Given this list of marker genes Txk, Nfatc3, Ccl5, Naa10, Ddx50, Bin1, Pnisr, Ubald1, Nck1, Pnrc1, Dnajc10, Cotl1, Macf1, Tbc1d10c, Trmt112, Arglu1, Hmgb1, Nop10, Smc6, Snapc5, Actg1, S1pr1, Pdcd4, Ugcg, Pink1 (PTEN induced putative kinase 1), Tmed10, Eif3i, Thy1 (NCBI Gene Id 21838), Gimap7, Lef1, AB124611 (NCBI Gene Id 382062), H2az2, S100a10, Map4k4, Nr4a1, Stk17b, Themis, Ttc3 (tetratricopeptide repeat domain 3), Fyb1, Arl5c, Cxcr4, Pglyrp1, Ccni, Eef1b2, Tcf7 (transcription factor 7, T cell specific), Tacc1, Gimap3, Acp5, Calm2, Sorl1, Eno1, Klf6, Cd52, Septin1, Add3, Rasgrp2, Slc25a4 (solute carrier family 25 (mitochondrial carrier, adenine nucleotide translocator), member 4), Abca2, Jak1, H2aj, Adgre5, Sh3kbp1, Dhrs7, Klrd1, Btg2, Arhgdib, Slc38a1, Ctsd, Cenpa, Rgs2, Stat4, Slc25a3, Id3, Hmgb2, Gmfg, Crip1, Rack1, Ogt, Chd9, Lcp1, Ncor1, Foxp1, Ighm, Ifi27, Cox8a, Rp9, Foxo1, Klf2, Ets1, Ifngr1, Tubb5, Tecpr1, Sh3bgrl3, Acyp1, Chd3, Cd3g (CD3 antigen, gamma polypeptide), Pfn1, Sfpq, Izumo4, Ddx17, Cd3d, Hnrnpr, Cd160, H2az1, U2af2 (NCBI Gene Id 22185), Iqgap2, Ypel3, Nsd1, Kif21b, Eef2, Fxyd5, Nherf1, Emp3, Entrep3, Neurl3, Lrrc8c, Rac2, Zfp36l2, Cox7a2l, Smad7 (NCBI Gene Id 17131), Myh9, Ptp4a3 (protein tyrosine phosphatase 4a3), here is a description of the gene set: from publication Cui A, Huang T, Li S, Ma A, Pérez JL, Sander C, Keskin DB, Wu CJ, Fraenkel E, Hacohen N (PMID 38057668) studied in species Mus musculus Genes negatively differentially expressed in cell type: γδ T cell upon treatment with cytokine: IFN-α1 in mouse lymph nodes in vivo. Cytokines mediate cell-cell communication in the immune system and represent important therapeutic targets. A myriad of studies have highlighted their central role in immune function, yet we lack a global view of the cellular responses of each immune cell type to each cytokine. To address this gap, the authors created the Immune Dictionary, a compendium of single-cell transcriptomic profiles of more than 17 immune cell types in response to each of 86 cytokines (>1,400 cytokine-cell type combinations) in mouse lymph nodes in vivo. A cytokine-centric view of the dictionary revealed that most cytokines induce highly cell-type-specific responses. For example, the inflammatory cytokine interleukin-1β induces distinct gene programmes in almost every cell type. A cell-type-centric view of the dictionary identified more than 66 cytokine-driven cellular polarization states across immune cell types, including previously uncharacterized states such as an interleukin-18-induced polyfunctional natural killer cell state. Mouse Gene Set: CUI_T_CELL_GD_IFNA1_RESPONSE_DN